Given this list of marker genes NUP54, POM121, NDC1, RAN, NUP160, NUP107, NUP62, TNPO1, AHCTF1, UBE2I, NUP98, RCC1, KPNB1, NUP58, NUP205, SEH1L, NUP43, NUP35, SEC13, NUP37, RANGAP1, NUP85, NUP93, NUP133, SUMO1, NUP155, NUP188, here is a description of the gene set: Human Gene Set: REACTOME_POSTMITOTIC_NUCLEAR_PORE_COMPLEX_NPC_REFORMATION Postmitotic nuclear pore complex (NPC) reformation studied in species Homo sapiens